Given this list of marker genes FANCF, MSX1, ITPR1, MAP1B, WDPCP, NRAS, SQSTM1, VPS13D, NIPA2, TWNK, CRIPTO, GRIA3, FBXW7, SLC2A1, MKRN3, NDN, BBS7, TP63, JMJD1C, ARX (NCBI Gene Id 619216), HCCS, FOXP2, NTN1, MT-ND5, APC, SPART, C9orf72, COMT, GNPTAB, MT-TS2, CHRNA7, NSD1, FMR1, NIPA1, PIEZO1, SRY, MT-ND6, TARDBP, HNRNPA1, FGF8, B4GAT1 (NCBI Gene Id 11041), MT-ND1, PMPCA, SOS1, NOTCH3, GLI2, DISP1, MT-TF, MYT1L, ORC1, NSUN2, ALDOA, CEP19, ADA2, KRAS, DNAJC21, RAF1, SOS2, ORC6, PIEZO2, KCNJ2, GMNN (NCBI Gene Id 51053), HIRA, PI4KA, POMT2, KCNJ5, CRPPA, ABCD1, ASL, ARL6, DVL3, PRNP, DGCR8, CYLD, MT-CO1, CFAP418, MAPT, NF1, GJC2, BBS5, SPTBN1, MAN2B1, LZTR1, EHMT1, CBL, PIK3C2A, SYN1, WNT5A, PWRN1, ZFYVE26, SLC2A10, WIPF1, CKAP2L, ARVCF, PLCH1, TRIM32 (tripartite motif containing 32), HTT, SMAD4, WAS, BBS12, GCLC, SPRED1, LEMD3, SOX2 (NCBI Gene Id 6657), MT-TQ, MT-TH, HDAC8, HERC2, SEC24C, MED13L, FLT4, SNORD115-1, SBF2, MT-CO3, RXYLT1, STAG2, PIGH, FKTN, SIX3, ALMS1, TINF2, SPTAN1, TBX1, RPS23, PTCH1, GRIN2A, BBS9, ADGRG1, COL4A1, PCGF2, KIF11, FUS, ESS2, JAG1, DARS2, POMGNT2, LZTFL1 (NCBI Gene Id 54585), MTHFR, PRKAR1B, TTC8, TSC2, SPRED2, AUTS2, SMC1A, LAS1L, MT-TL1, FIBP, CHSY1, IFT27, GALT, SNRPN, OCA2, GABRA1, CEP290, KCNC3, PNKP, PRMT7, FARSB, HAL, LIG4, HMGA2, DGCR2, NECTIN1, CYP27A1, RNF168, TERT, CHMP2B, DGCR6, ANGPT2, DPYD, JRK, AMER1, BBIP1, SRPX2, LTBP4, SMPD1, TUBB3, DAG1, ORC4, PSMD12, AMACR, BBS2, BLM, SPG11, SUGCT, PTDSS1, CNKSR2, GDI1, EFHC1, SARDH, STIL, MT-CO2, RASA2, THOC6, SRP54, TRIO, UFD1, POMT1, ALDH18A1, MKKS (MKKS centrosomal shuttling protein, NCBI Gene Id 8195), STIM1, ATP7A, TCF4, TMEM106B, RNU4ATAC, TERC, LARGE1, AFF2, RRAS2, PLA2G6, TMEM94, APC2, SNORD116-1, BPTF, PWAR1, IRF6, MRAS, SLC25A15, SIL1, SIX6, HNRNPA2B1, PSEN1, VPS41, TREM2, TUBG1, BBS10, SLC2A3, OTC, GABRG2, PAPPA2, GRB10, RDH11, DMD, SH2B1, NPHP1, SBDS, TUBB4A, FRMD5, GABRB3, SDCCAG8, TGIF1, IFT172, TUBB2B, MAP2K2, CLTCL1, CHCHD10, RREB1, COQ2, H19, TSC1 (NCBI Gene Id 7248), WDR1, DIS3L2, CCDC28B, GLUD1, MBTPS2, SMARCA2, DVL1, FKRP, GRN, DNAAF4, VCP, SCAPER, THRB, TMEM63A, BBS1, IFNG, PRKD1, NTRK1, FGFR1, HINT1, MICU1, SCLT1, IGF2, RRAS, TCF12, SIM1, MT-ND4, TCTN3, B3GALNT2, RAD51, RIT1, NPAP1, DNAL4, SPG7, OPA3, ELN, EXTL3, CDON, COX7B, MAGEL2, YY1AP1, MLXIPL, TBK1, NDUFB11, NODAL, LTBP1, POMK, CDC45, MTOR, DPP9, GP1BB, KAT6B, ACTG1 (actin gamma 1), CA2, MT-TW (NCBI Gene Id 4578), DLL1, UBE3B, ZIC2, KLF13, EBF3, PRRT2, SC5D, MYCN, CDT1, MYO5A, GAS1, KCNA1, LYST, PTPN11, CBS, MORC2, ASPA, DCC, MID1, KIFBP, FOXH1, FZD2, ACTB, SHH (sonic hedgehog signaling molecule), CACNA1H, MKS1, POMGNT1, CDC6, BBS4, IFT74, CACNA1A, here is a description of the gene set: Specific learning disability Human Gene Set: HP_SPECIFIC_LEARNING_DISABILITY species: Homo sapiens Impairment of certain skills such as reading or writing, coordination, self-control, or attention that interfere with the ability to learn. The impairment is not related to a global deficiency of intelligence.